The following is a description of a gene set: Human Gene Set: HP_RECTAL_POLYPOSIS species: Homo sapiens The presence of multiple rectal hyperplastic/adenomatous polyps. Rectal polyposis, and this is the list of marker genes: BMPR1A (bone morphogenetic protein receptor type 1A), GREM1, MUTYH, ENG, SMAD4